Given this list of marker genes SGCE, FRZB, MFNG, ITGA8, MTA2, PITX3 (NCBI Gene Id 5309), RPS6KA4, UBE2G2, PDE6G, COL11A2, RRAGD, H2BC12, FAT1, here is a description of the gene set: from publication Davies FE, Dring AM, Li C, Rawstron AC, Shammas MA, O'Connor SM, Fenton JA, Hideshima T, Chauhan D, Tai IT, Robinson E, Auclair D, Rees K, Gonzalez D, Ashcroft AJ, Dasgupta R, Mitsiades C, Mitsiades N, Chen LB, Wong WH, Munshi NC, Morgan GJ, Anderson KC (PMID 12947006) Human Gene Set: DAVIES_MULTIPLE_MYELOMA_VS_MGUS_UP To define specific pathways important in the multistep transformation process of normal plasma cells (PCs) to monoclonal gammopathy of uncertain significance (MGUS) and multiple myeloma (MM), we have applied microarray analysis to PCs from 5 healthy donors (N), 7 patients with MGUS, and 24 patients with newly diagnosed MM. Unsupervised hierarchical clustering using genes with a large variation across all samples defined 2 groups: N and MGUS/MM. Supervised analysis identified genes differentially expressed between N and MGUS and genes differentially expressed between N and MM, 197 of which were also differentially regulated between N and MGUS. Only genes were differentially expressed between MGUS and MM samples, indicating that the differences between MGUS and MM are smaller than those between N and MM or N and MGUS. Differentially expressed genes included oncogenes/tumor-suppressor genes (LAF4, RB1, and disabled homolog 2), cell-signaling genes (RAS family members, B-cell signaling and NF-kappaB genes), DNA-binding and transcription-factor genes (XBP1, zinc finger proteins, forkhead box, and ring finger proteins), and developmental genes (WNT and SHH pathways). Understanding the molecular pathogenesis of MM by gene expression profiling has demonstrated sequential genetic changes from N to malignant PCs and highlighted important pathways involved in the transformation of MGUS to MM. Genes up-regulated in multiple myeloma (MM) compared to monoclonal gammopathy of uncertain significance (MGUS). studied in species Homo sapiens